The following is a description of a gene set: The proliferation of cells in the trophectoderm. Human Gene Set: GOBP_TROPHECTODERMAL_CELL_PROLIFERATION species: Homo sapiens, and this is the list of marker genes: ZPR1, GRN, IGF1, COPS2, ACVR1C